Given this list of marker genes NOLC1, KBTBD8, KLHL12, EDNRA, LRP6 (LDL receptor related protein 6), POLR1B, WNT8A, PEF1, SFRP1, SOX9, TCOF1, GSC, FUZ, EDN1, PDCD6, here is a description of the gene set: The formation of the specialized region of ectoderm between the neural ectoderm (neural plate) and non-neural ectoderm. The neural crest gives rise to the neural crest cells that migrate away from this region as neural tube formation proceeds. Human Gene Set: GOBP_NEURAL_CREST_FORMATION species: Homo sapiens